The following is a description of a gene set: part of: SARS-CoV-1-host interactions Reactome Pathway: SARS-CoV-1 modulates host translation machinery species: Homo sapiens Severe acute respiratory syndrome coronavirus type 1 (SARS-CoV-1) nonstructural protein 1 (nsp1) and nucleocapsid protein (N) disrupt mRNA translation upon SARS-CoV-1 infection in human cells., and this is the list of marker genes: RPS4Y2, HNRNPA1, RPS12, RPS2, RPS18, RPS26, RPS16, rep, EEF1A1, RPS9, RPS20, RPS27L, RPS15, RPS21, 1a, RPS17, RPS4X, RPS5, RPS7, RPS25, RPS6, RPS14, RPS4Y1, RPS29, RPS19 (ribosomal protein S19), 18S rRNA, FAU (NCBI Gene Id 55430), RPS10, RPS13, RPS27, RPS28, RPSA, RPS8, RPS23, RPS11, RPS3A, RPS3, RPS24, RPS27A, N, RPS15A